Given this list of marker genes Col12a1, Atp2b4, Nr6a1, Ccdc51, Gm2a, Htr1d, Ifnar1, Tpbgl, Zfp275, Tmem9b, Ppp2r2c, Trmt2b (NCBI Gene Id 215201), Zfp384, Stk40, Nfat5, Pkp1, Cep350, Cd79a (CD79A antigen (immunoglobulin-associated alpha)), Hoxc10, Matn1, Adam19, Necab1, Plpp4, Cmtm4, Aff4, BC031181 (cDNA sequence BC031181), Otof, Iqsec1, Tiprl, Cyp51, Nsun7, Dclk1, Tomt, Clmn, Ramp1, Pkn2, Ppp2r5e, Atp6ap2, Lsm11, Zfp516, Sla, Me1 (NCBI Gene Id 52233), Ttc39b, Phlpp1, Pld2, Lman2l, Ptpn5, Hoxc5 (homeobox C5), Hap1, Pde7a, Klhl24, Sobp, Aph1c, Aph1b, Dffb, Plk3, Zfp704, Zswim9, Amy2a4, Ksr1, Slc10a5, Prkcb, B4gat1, Tubg1, Slc16a5, Pate2, Fam222a, Zfc3h1, Helb, Slc28a2b, Smarce1, Fosl1, Ssh2 (slingshot protein phosphatase 2), Myo1c, Amy2a2, AW554918, Med28, Dnajc6, Clock, Kat6a, Sumo3, Trip4, Plekhs1, Efcab2, Mtmr6, Syn1, Rasa1 (RAS p21 protein activator 1), Cx3cl1, Obox5, Rab43, Fam241a, Zfp239, Slc30a2, Plod2, Ankfy1, Kif3b, Mmp24, Cap1, Nfib, Mast4, Amy2a3, Itgb3, Nefl, Abcb9, Jph4, Ldlrad2, Kdm1b, Decr1, Trim26 (tripartite motif-containing 26), Slc35e2, Grsf1, Lyz1 (NCBI Gene Id 17110), Lcn4, Tal2, Or5b95, Eeig2, Rbm8a, Stx12, Rabgap1, Ccdc93, Mfsd14b, Rhbdl3, Ceacam2, Sult1b1, Rnf182, Ldha, Adnp2, Hoxa1, Cacna2d2, Slc30a1 (NCBI Gene Id 98435), Stk32c, Zbtb16, Ky, Ddit4l, 2610028H24Rik, Foxk1 (NCBI Gene Id 17425), St8sia6, Gpkow, Gpx2, Acvr1b, Tlr3, Pde2a, Ust, Klk5, Slc28a2, Ints2, Hycc2, Zfp981, Golga7b, Kdm2a, Ercc6l2, Gtf2e1, Rnf152, Commd9, Mog, Chl1, here is a description of the gene set: Genes predicted to be targets of miRBase v22 microRNA mmu_miR_7090_5p in miRDB v6.0 with MirTarget v4 prediction scores > 80 (high confidence targets). studied in species Mus musculus from publication Chen Y, Wang X (PMID 31504780) Mouse Gene Set: MIR_7090_5P